The following is a description of a gene set: Human Gene Set: HP_ABNORMAL_FOOT_BONE_OSSIFICATION studied in species Homo sapiens An abnormality of the formation and mineralization of any bone of the skeleton of foot. Abnormal foot bone ossification, and this is the list of marker genes: FLNA, EIF2AK3, SLC35D1, PTH1R, INPPL1, FLNB, COL2A1, HOXA13 (homeobox A13), TRIP11, ACVR1, EBP, MATN3, CANT1